The following is a description of a gene set: Isovaleric acidemia is an inborn error of metabolism that arises due to mutations in isovaleryl-CoA dehydrogenase (IVD), a mitochondrial enzyme that catalyzes the third step in the catabolic pathway for leucine, the conversion of isovaleryl-CoA and FAD to beta-methylcrotonyl-CoA and FADH2. Isovaleric acidemia has variable clinical presentation and lacks a clear correspondence between genotypic alterations and phenotypic outcome. Symptoms include vomiting, seizures, low energy, and a characteristic sweaty foot odor due to presence of isovaleric acid, 3-hydroxyisovaleric acid, isovarleryl-glycine and isovaleryl-carnitine in blood and urine. Reactome Pathway: Isovaleric acidemia studied in species Homo sapiens part of: Diseases of branched-chain amino acid catabolism, and this is the list of marker genes: IVD